The following is a description of a gene set: Human Gene Set: GAO_LARGE_INTESTINE_ADULT_CE_OLFM4HIGH_STEM_CELL species: Homo sapiens from publication Gao S, Yan L, Wang R, Li J, Yong J, Zhou X, Wei Y, Wu X, Wang X, Fan X, Yan J, Zhi X, Gao Y, Guo H, Jin X, Wang W, Mao Y, Wang F, Wen L, Fu W, Ge H, Qiao J, Tang F (PMID 29802404), and this is the list of marker genes: APBB1, TTK, C7, B4GALNT4, DUSP16, VPS33B-DT, IFIT2, C11orf96, HSD17B7P2, ENSG00000249328, CATSPERE, WFDC3, PRND, RAB36, B4GALT6, TUBA8, DNAJC9-AS1, CMYA5, SLC12A4, GPC6, LTB, OVCH1, RPS2P32, LYRM9, CTIF, ZNF324, NFATC4, CEP290, TLR1, PPIEL, TBX2, MSX1, INKA2-AS1, KLHL32, LINC01179, AUNIP, QRFPR, ANKDD1B, AKR1D1, ARRB2, NANOS1, CD300E, HACE1, LINC01191, TCTN2, IFIT3, APOBEC3A, SNTA1, GINS1, C14orf132, OR1N2, ENSG00000236064, MPP7, IL10RB-DT, CCNP (cyclin P), PDZD4, TSPYL5, MAMLD1, MAPK11, BCL6, BASP1-AS1 (BASP1 antisense RNA 1), VASN, ATP6V0D2, DHX57, HOXD4, QKI, BEGAIN, MS4A10, CTSZ, POLR3G, TBKBP1, SDK1, PRR12, UHRF1, UNC5CL, GNA12, PFN1P2, CDKL2, LINC00471, PMCHL2, CACTIN, LINC01492, LINC02245, TNFSF15, SLC24A4, GTF2IRD1, HLA-DRB6, HAUS8, CDC45, SKI, LINC02016, WNT9B, HSPA4L, COL6A4P2, MYT1, CAND2, LINC00174, ZNF674, ZNF227, NPHP4, RAMP3, DNAH5, CPED1, ABCG1, CTU1, FPR1, DLST, CECR2, NKX3-1, MSLN, LRRC73, MUC5AC, BAG2, CLEC16A, CCDC80, ZNF674-AS1, ZNF709, CBX7, ZDBF2, CX3CL1, ZC3H7B, PRR7, RAB11FIP3, CD109-AS1, PAXBP1-AS1, RHBDL3, OR7D2, SSPN, PLEK, AMER2, LINC01426, ADHFE1, TMEM47, DGKG, SERPINI1, ZNF316, BNC2, ZNF653, ZFPM1, HLA-DQB1, LINC01247, MPL, SYNPO (NCBI Gene Id 11346), PHLDA3, LRRC20, LINC00598, FAM86B3P, LST1 (leukocyte specific transcript 1), TMEM178A, LINC02893, IL4I1, PIPSL, SAP25, BLM, SPESP1, UBOX5, HAR1A, AP3M2, ENTPD1-AS1, CCDC170, RDH8, TRNP1, NRIP2, DGAT2, PRPF4, LMNB1, OBSCN, C2CD4C, ZXDB, OR7E12P, MYBPC3, LINC03099, ZNF697, GOLGA8H, KCNQ4, SLC7A14, RALYL, TIMP4, CMKLR2-AS, PLXDC1 (NCBI Gene Id 57125), FAM185A, ACSL1, CLEC19A (C-type lectin domain containing 19A), CD36, PPEF2, CD28, DAND5, GSDMA, ZNF845, WFDC10B, LIAT1 (ligand of ATE1), ABCA9, PDGFRB, MLXIPL, AOC3, IRAK2, ATP1A2, MEOX2, FFAR2, MEIS3P1, SYNPO2L, SERPINB5, MSANTD4, SLC18A1, LINC00485, CACNA1C, ST3GAL5, PKP1, LIMS2, CGNL1, TMEM239, CEP152, ZNF618, HCN3, CNNM1, SCAND3, CDC20B, GREM1, CDH6, LINC02202, ZNF467, KLF7, ADAP2, GATA2, ENSG00000255537, NIN, LINC00970, CPT1B, SH2D7 (NCBI Gene Id 648042), DCDC2, TMEM102 (transmembrane protein 102), CMPK2, HEG1, AIRE, MAP2, POM121L10P, LIG4, MTUS2 (microtubule associated scaffold protein 2), SV2B, ABCB6, KRBOX4, CHIC1, TEX11, MYH11, IL23A, ZNF773, GUCY1A1, C1orf226, CHST13, NRGN, RBBP9, SLC1A2, SLC22A8, TEKT5, HCAR2, DCBLD1, GRIP2, CYP2B6, MEX3B, EPGN, GAS6-DT, RBP7, RIPOR2, IKZF4, ELOVL5, SLC9A7P1, KCNH8 (potassium voltage-gated channel subfamily H member 8), ZNF234, COL5A1, ZNF740, COL4A6, ANKS1B, OXGR1, ALKBH1, LINC00311, LINC01551, CPB2-AS1, HIVEP1, LINC01315, TMEM91, FAM89A, ENSG00000274253, INTS2, GFI1, CASQ2, KCNA7, KIF14, OR5M9, TMEM30A-DT, BTBD8, CTBP1-AS, KRT18P55, PREX1, BARX2, PLA2G4E, ADH1A, LIPE, VMAC, TMEFF2, OGFR, ADGRF2P, C5AR1, LINC02681 (NCBI Gene Id 101927419), SCN11A, AADACP1, FILIP1L, SNTN, ZNF17, LINC01448, EFR3B, HTR4, PCED1B, ANKMY1, SLC16A14, HMCN2, LATS2, IL6ST-DT, PPP1R37, TDRD5 (NCBI Gene Id 163589), NBR2, MS4A7, KIF21B, GBGT1, PSORS1C1, KCNA5, KCNIP4, LINC00887, C16orf95, HNRNPKP3, FOXL2NB, OXER1, ANTXR1, CENPE, SENP3, CXCL5, RNF215, ZNF334, BMAL1, ZDHHC8BP, PHKA1, FOXP2, MEX3D, BCAM, POLQ, LINC02087, NFATC1, WNT11, GJC1, RBPMS, TRPV6, CACNA1I, ZNF565, EPG5, CNBD2, TOX2, EYS, RBM26-AS1, RMI2, TMEM169, LOXL1, AQP11, C2orf74, LINC01012, GARIN5A, THAP8, RCAN2, ENSG00000290498 (NCBI Gene Id 101928535), PLXNC1, LINC01804, ZNF25, WIPF3, KLHL25 (NCBI Gene Id 64410), TBC1D25, ZNF75D